Given this list of marker genes PTPN22, HLA-B, TNFRSF1A, ANKRD55, IL36RN, STAT4, IL2RA, TOM1, MEFV, PTPN2, IL2RB, CD247, PTPN6, here is a description of the gene set: Oligoarthritis A type of arthritis that affects up to four joints in the first six months of disease. Human Gene Set: HP_OLIGOARTHRITIS species: Homo sapiens